Given this list of marker genes ULK2, ADRM1, PSMA5, MAP2K2, DVL3, GNAQ, PSMA8, KIF5C, CAPN1, PSMA3, CALML5, FRAT2, TUBB2A, PSENEN, AXIN1, AMBRA1, BACE1, TUBB6, AXIN2, GRIN2A, PPP3CC (protein phosphatase 3 catalytic subunit gamma), VDAC1, PPIF, CASP9, GRIN2D, CYCS, APOE, CALM3, PIK3R3, GRIN1, CHRNA7, PSMA1, NFKB1, CSNK1A1, FZD9, MTOR, AKT1, PPP3CB, WNT7A, FZD3, CALML6, TUBA3D, PTGS2, SLC25A6, MAP2K1, PSMD6, CSNK1A1L, WIPI1, APC, PIK3R1, WNT5B, DKK4, NOX4, CYBB, PSMB5, PIK3CA, PSMC1, WNT5A, PSMD8, APBB1, APP, CSNK2A2, FAS, TNFRSF1A, PSMB4, ADAM10, TUBA1A, MAPK9, ATF6, PIK3CD (NCBI Gene Id 5293), PSMA2, WNT7B, LRP6, WNT4, PSMD1, PSMD14, CSNK1E, SLC25A4, ITPR2, FZD6, PLCB1, MAPK3, BAD, PSMD12, TUBAL3 (NCBI Gene Id 79861), MAPK1, CALM2, TRAF2, XBP1, ATG2A, PSEN2, GSK3B, INS, HSD17B10, RB1CC1, GRIN2C, PSMC4, ATG13, LRP5, ATF4, WIPI2, PSMC6, TUBB, EIF2S1, CHUK, MCU (mitochondrial calcium uniporter, NCBI Gene Id 90550), ITPR3, CSNK2A1, FZD10, NRAS, EIF2AK3 (NCBI Gene Id 9451), ATP2A3, IL1A, CSNK2B, ATG2B, SLC25A31, APH1A, TUBB4A, AKT2, ATP2A2, HRAS (HRas proto-oncogene, GTPase), PSMB7, FZD2, DDIT3, TUBA3C, WNT3A (NCBI Gene Id 89780), MAPK8, PPP3R2, APAF1, FZD1, CAPN2, AGER, TUBB8, PLCB2, WNT10B, SLC25A5, MAPT, IDE, PSEN1, PLCB3, PSMC5 (proteasome 26S subunit, ATPase 5), CASP7, PIK3CB, NOX1, KRAS, FADD, ULK1, TUBA8, RTN3, CDK5R1, ADAM17, CSNK2A3, AKT3, PPID, GAPDH, CACNA1D, PSMD3, PSMD7, NOS2, WNT6 (Wnt family member 6), CACNA1C, ATP2A1, PIK3R2, KLC4, RTN4, KLC3, KLC1, NOS1, TUBB4B, WNT16, LRP1, APC2 (APC regulator of WNT signaling pathway 2), SNCA, NAE1, TUBB3, WNT10A, WNT1, PSMB3, PSMC2, PPP3CA, BECN2, PSMD13, KIF5B, RAF1, PSMD4, CALML3, MAPK10, ATG14, LPL, ATG101, CALML4, PSMA4, IKBKB, DVL1, CTNNB1, PPP3R1, BID, IRS1, FRAT1, TUBA1B, CDK5, ARAF, PLCB4, TUBA1C, CASP3, ITPR1, KLC2 (NCBI Gene Id 64837), FZD7, INSR, RYR3, MME, PIK3R4, PSMA7, PSMB6, CALM1, PSMA6, PSMB1, DKK2, NRBF2, SFRP4, IL1B, KIF5A, IRS2, TUBB1, CASP8, MAP3K5, BRAF, DVL2, NCSTN, GRIN2B, EIF2AK2, MAP2K7 (NCBI Gene Id 5609), ERN1, TUBA3E, FZD5, GPR83, RELA, IL6, APH1B, PSMC3, SEM1, VDAC3, BECN1, FZD8, CACNA1F, PSMB2 (proteasome 20S subunit beta 2), IRS4, DKK1, WNT3, WNT11, PIK3C3 (phosphatidylinositol 3-kinase catalytic subunit type 3), TNF, TUBB2B, WNT2, PSMD2, CSF1, WNT2B, TUBA4A, PSMD9, CACNA1S, VDAC2, here is a description of the gene set: species: Homo sapiens Alzheimer's disease Human Gene Set: WP_ALZHEIMERS_DISEASE